Given this list of marker genes TP53, RPS6, SLC11A2, PRKAA1, CUL3, PDHA2, PRKAB1, PRKAG1, SLC2A1, KEAP1, PDK1, VEGFA, ACACB, PDHA1, ACACA, HIF1A, LDHA, PDHB, EGLN1, NFE2L2, here is a description of the gene set: Human Gene Set: WP_HEREDITARY_LEIOMYOMATOSIS_AND_RENAL_CELL_CARCINOMA_PATHWAY Hereditary leiomyomatosis and renal cell carcinoma pathway species: Homo sapiens